The following is a description of a gene set: Mouse Gene Set: CUI_MONOCYTE_IFNA1_RESPONSE_UP studied in species Mus musculus Genes positively differentially expressed in cell type: Monocyte upon treatment with cytokine: IFN-α1 in mouse lymph nodes in vivo. Cytokines mediate cell-cell communication in the immune system and represent important therapeutic targets. A myriad of studies have highlighted their central role in immune function, yet we lack a global view of the cellular responses of each immune cell type to each cytokine. To address this gap, the authors created the Immune Dictionary, a compendium of single-cell transcriptomic profiles of more than 17 immune cell types in response to each of 86 cytokines (>1,400 cytokine-cell type combinations) in mouse lymph nodes in vivo. A cytokine-centric view of the dictionary revealed that most cytokines induce highly cell-type-specific responses. For example, the inflammatory cytokine interleukin-1β induces distinct gene programmes in almost every cell type. A cell-type-centric view of the dictionary identified more than 66 cytokine-driven cellular polarization states across immune cell types, including previously uncharacterized states such as an interleukin-18-induced polyfunctional natural killer cell state. from publication Cui A, Huang T, Li S, Ma A, Pérez JL, Sander C, Keskin DB, Wu CJ, Fraenkel E, Hacohen N (PMID 38057668), and this is the list of marker genes: Gbp3, Rnf213, Usp25, Selenow, Tpm3, Oasl1, Igtp, Hnrnph2, Macroh2a1, Uba7, Gyg1, Rin2, Nampt, Irgm1, Gbp5 (guanylate binding protein 5), Parp12, Il18, Zyx, Stx11, Cggbp1, Fam241a, Tor3a, Slfn8, Prpf38a, Camk2d, Plaur (NCBI Gene Id 18793), Tcstv4, Fgl2, Plac8 (placenta-specific 8), Nod1, Znfx1, Psma7, Sgcb, Ms4a4c, Pdia6, Pkib, Hmgn3, Mndal, Psmb10, Dhx58, Tap2, Manf, Ifi205, Cnp, Itpr1, Dbnl, Max, Irf5, Gbp2, Ifit1, Naa20, Arf4, Dop1b, Pdia3, Morf4l2, Gmppb, 9930111J21Rik2, Bbx, Mgst1, Xdh, Apobec3, Nt5c3, Trim30b, Calr, Prm1, Pml, Tapbp, Treml2, Stat1, Mpeg1, Cndp2 (CNDP dipeptidase 2), Maf, Isg20, Gbp4, Cldnd1, Ifi213, Tmem219, Dnajb11, Hk3, Ranbp2, Fam111a, Ube2l3, Fndc3a, Naa25, Bst2, Actr3, Ccl2, Grina, Rbms1, Dck, H2-T23, Ifi214, Nqo2, Nmral1, Ankfy1, Slfn4, Azi2, Slc25a22, Sell, Atp6v1b2, Helz2 (helicase with zinc finger 2, transcriptional coactivator), Cycs, Psmb8, Sp110, Sp140, Psme2, Psma3, Ilrun, Parp11, Ifi206, Stx3, Tor1aip1, Slc2a6, Stxbp3, Ehd4, Tle3, Ddx60, Ccr1, H3f3b, Morc3, Gbp7, Ppa1, Epsti1, Actg1, Qpct, Tpst2, Ifi209, Slco3a1, Ms4a6c, Chil3, Mthfr, Parp14, Itm2b, Cxcl10, Tcirg1, Iigp1, Gpsm2, Usp18, Trim30a (tripartite motif-containing 30A), Cmpk2, Vcan, Mov10, Socs1, Ms4a6d, Ndufs4, Ifi211, Prkx, Ccdc86, Vapa, Samhd1, Sap30, Arpc2, Jpt1, Stard3, Cmklr1, Tap1, Srsf3, Trafd1, Lgals3, Slfn2, Mitd1, Dtx3l, Trim30c, Trim34a, Svbp, Hdac1, Tspo, Il15 (interleukin 15), Sumo1, Tbc1d1, Cd300lf, Fcgr1, Marchf5, Tbl1x, Dek, Oasl2, Eif2ak2, Prdx6, Chpt1, Nes, Adar, Ifit2, Ppp1r2, Gbp9, Serpina3g, Bag1, Tapbpl, Snx10, Mxd1, Vrk1, Msrb1, Slc12a9, Aldh1b1, Rigi, Txndc9, Daxx, Rilpl1, Il1rn, Peli1, Slpi, Phf11d, Rap2c, Ifi208, Ifitm6 (interferon induced transmembrane protein 6), Pnp, Arf1, Ifit1bl1, Rsad2, Lgals1, Fes, Pttg1, Pfkp, Ifi203, Evl, Chmp4b, Cfp, Oas1a, Samd9l, Hck, Selenom, H2-T22, Capza2, Akr1a1, Ethe1, Glrx, Sp100, Ly6c2, Rnpep, Ddx4, Tmem184b, Psmb9, Clec2d (NCBI Gene Id 93694), Ifi204, Arfgef1, Tor1aip2, Sppl2a, Prdx1, Stat2, Tomm70a, Phf11b, Fcgr4, Lgals3bp, Gch1, Clic4, Cd69, Casp4, Slfn1, Rars1, Nsmaf, Grn, Ly86, Trabd, Irf7, Skap2, Ifi207, Psma5, Sema4d, Psme1, Irak2, Ccdc25, Dpysl2, Aida, Ifi35, C1galt1c1, Lgals9, Nono, Herc6, Rtp4, Pgap2, Txn1, Tfg, Dnaja1, Dnaja2, Slfn9 (NCBI Gene Id 237886), Gatm, Znhit1, Nmi, Ifitm3, Scimp, Slc25a12, Glipr2, Slfn5, Mpp1, Atp8b4, Pkm, C3, Anxa2, Arl6ip1, Slc15a3, Trim30d, Tmem106a, Creld2 (cysteine-rich with EGF-like domains 2), Capg, BC005537, Mx1, Hmox2 (heme oxygenase 2), Tmbim6, Ube2l6, Phf11a, Mlkl (mixed lineage kinase domain-like), Ctsc, Psma4, Xaf1, Rab27a, Ubc, Mbd2, Plod3, Ifi47, Ly6a, Tmsb10, Cd164, Ifit3b, Klrk1, Casp3, Sdcbp (NCBI Gene Id 53378), Ifih1, Copg2, Isg15, Tmpo, Ly6e, Zbp1, Rbm43, Lpxn, Oas3, Lamp2 (lysosomal-associated membrane protein 2), Cd47, Hspa5, Ifit3, Themis2, Tnfsf10, Casp1, Ogfr, Pdcd10, Ms4a6b (membrane-spanning 4-domains, subfamily A, member 6B), Snx2, Frmd4a, Srsf7, Ass1, Naaa, Calhm6, Tpm4, Myd88, Sdc3, Irgm2 (immunity-related GTPase family M member 2)